The following is a description of a gene set: Mouse Gene Set: GOBP_NEGATIVE_REGULATION_OF_HEPATOCYTE_APOPTOTIC_PROCESS Any process that stops, prevents or reduces the frequency, rate or extent of hepatocyte apoptotic process. studied in species Mus musculus, and this is the list of marker genes: Igf1r, Adar, Rb1, Lims1, Prkaa1, Ppara, Prkaa2, Cflar